Given this list of marker genes FGD4, PLEKHG4B, TRIO, RHOF, SPRY3, PLEKHG1, DOCK8, OPHN1 (oligophrenin 1), CYTH2, RAP1GAP2, ARHGEF19, ARHGAP4, ARHGEF4, RAF1, MYO9A, PLEKHG3, PIK3CB, FAM13B, ARHGAP42, CD2AP, ARHGEF2, SPATA13, DLC1, LPAR2, CYRIB, F2R, DENND4B, MMD2, CRKL, SCAI, ARHGAP12, ARHGAP40, ARFGEF1, KRAS, RASGEF1A, SIPA1L1, FLOT1, FAM13A, FGF10, PICALM, CSNK1A1 (NCBI Gene Id 55416), FGD3, RTN4R, FOXM1, SSX2IP (SSX family member 2 interacting protein), TNS3, CYTH1, RASAL1, CYTH3, PDCD10, ARFGEF2, ADGRG1, ADCYAP1R1, SLIT2, CDKL5, ARHGEF11, EPO, RTN4, SOS1, AMOT, ARHGAP23, KITLG, KALRN, ABR, CHN1 (chimerin 1), GPR4, FBXO8, ARHGAP6, ARHGEF12, DOCK6, DENND1A, ARHGAP26, DAB2IP, ARHGAP17, GABARAP, SYDE1, RALGAPA2, ARHGAP32, RACGAP1, TAGAP, CXCL13, VAV2, NOTCH1, RASA2, RASAL3 (NCBI Gene Id 64926), FXR1, DENND4C, STK19, EPS8L3, ARHGEF1, ARHGAP18, GARNL3, ARHGAP20, ARFGEF3, SPRY4, ARHGAP1, CDC42SE1, NF1, MIR21, SWAP70, ARHGEF25, PSD4, ARHGAP29, SPRY2, SHOC2, CADM4, ARHGDIA (Rho GDP dissociation inhibitor alpha), SYDE2, FLCN, ABRA, ARHGEF17, ARHGAP11B, TGM2, ARHGAP21, MAPRE2, OGT, IQSEC2, SH3BP1, PLEKHG6 (NCBI Gene Id 55200), MYO9B, ARHGEF10, ITGA3, ARHGEF10L, CBL, STARD13, NOTCH2 (NCBI Gene Id 55574), TSC2, RABGEF1, DENND4A, DEF6, GNA13, ARHGAP31, ARHGEF5, RELN (reelin), RHOU, VAV1, PRAG1, RDX, DOCK3, RASGRF1, DENND3, CRK, SPRY1, IQSEC1, RGL2, FGD1, ABCA1, CYTH4, PREX1, ARHGEF28, EPHB2, SQSTM1, MAP4K4, MAPKAP1, RASGRF2, STARD8, ARHGAP19, ARHGAP30, ARF6, NET1, APOE, GMIP (GEM interacting protein), ARHGAP10, CSF1, RASGRP1, CHN2, RASA4B, ARHGEF15 (Rho guanine nucleotide exchange factor 15), ARHGEF16, MIR223, PLEKHG5, CUL3, SEMA4D, FGD5, ARHGAP5, SRC, ITSN1, DOCK7, RASIP1, ARAP1 (ArfGAP with RhoGAP domain, ankyrin repeat and PH domain 1), TAX1BP3, MIR29B1, EPS8, NRP1, RASA3, ARHGAP44, RALBP1, EPS8L1, ERBB2, ARHGAP35, ARFGAP1, NUP62, GIT2, BCL6 (NCBI Gene Id 604), DOK7, RASA4, BCR, FRMD7, ITPKB, CDON, PKP4, ARHGAP8 (NCBI Gene Id 23779), SIPA1L3, ALS2, PREX2, ARHGEF18, KANK1, MCF2, PSD3, DOCK10, ARHGAP25, ARHGAP27, GBF1, AUTS2, LZTR1, FGD2, RAC1, RIPOR2, SYNPO2L, EPS8L2, NGF, RIT2, FNTA, ARHGEF9, MET (MET proto-oncogene, receptor tyrosine kinase), SRGAP2, MFN2, MADD, TIAM1, RALGAPB, RIPOR1, TGFB2, ECT2, LRP4, PLEKHG4, CCL19, KBTBD6, HEG1, KCTD13, ARHGEF3, ARHGAP11A, KBTBD7, STMN1, ARHGAP22, VAV3, ARHGAP45, TIAM2, PLXNB1, CGNL1, WNK1, OBSCN, MCF2L, F11R, ARHGDIB, APOA1, ITGAV, ARHGAP28, KIF14, DOCK2, KANK2, NGEF, PIK3CG, BNIP2, ARHGAP15, APOC3, ARRB1, IQSEC3, GPR55 (G protein-coupled receptor 55), PSD, FBP1 (fructose-bisphosphatase 1), STMN3, KCTD10, PPP2CB, ROBO1 (roundabout guidance receptor 1), SIPA1L2, LPAR1, STAMBP, GIT1, FERMT2, RABL3, ITGB1, ARHGEF40, TRIM67, TNFAIP1, ABL1, SGSM3, PSD2, DOCK11, AKAP13, DOCK9, ABL2, CCDC125, DNMBP, SIPA1, MYOC, F2RL1, TEK, CDC42SE2, NTRK1, SYNGAP1, RALGPS1, ARHGAP9, IGF1, COL3A1, RALGAPA1, RHOD, MAP2K1, SRGAP3 (NCBI Gene Id 9901), ARHGAP24, RAP1GAP, CCR7, ARHGAP39, here is a description of the gene set: Human Gene Set: GOBP_REGULATION_OF_SMALL_GTPASE_MEDIATED_SIGNAL_TRANSDUCTION studied in species Homo sapiens Any process that modulates the frequency, rate or extent of small GTPase mediated signal transduction.